The following is a description of a gene set: part of: Post NMDA receptor activation events Ca2+ influx through the NMDA receptor activates RAS guanyl nucleotide exchange factor RasGRF, which promotes formation of active RAS:GTP complexes. CaMKII, also activated by NMDA receptor-mediated Ca2+ influx, can contribute to activation of RAS/RAF/MAPK signaling by phosphorylation of RAF1. ERKs (MAPK1 and MAPK3), activated downstream of RAS signaling, phosphorylate ribosomal protein S6 kinases (RSKs), initiating activation of RSKs. Activated RSKs phosphorylate the transcription factor CREB1 at serine residue S133, thus stimulating CREB1-mediated transcription (De Cesare et al. 1998, Harum et al. 2001, Schinelli et al. 2001, Song et al. 2003). studied in species Homo sapiens Reactome Pathway: CREB1 phosphorylation through NMDA receptor-mediated activation of RAS signaling, and this is the list of marker genes: DLG1, CREB1, DLG3, NRAS, LRRC7, CAMK2D, CAMK2A, RPS6KA1, MAPK1, NEFL, ACTN2, RASGRF1, RPS6KA3, DLG4, RPS6KA6, GRIN2D, KRAS, HRAS, CALM1, RPS6KA2, CAMK2G, PDPK1, GRIN2B, MAPK3, GRIN1, CAMK2B, RASGRF2, DLG2 (NCBI Gene Id 283225)